Given this list of marker genes Tfap2a, here is a description of the gene set: Reactome Pathway: Specification of the neural plate border This event has been computationally inferred from an event that has been demonstrated in another species.<p>The inference is based on the homology mapping from PANTHER. Briefly, reactions for which all involved PhysicalEntities (in input, output and catalyst) have a mapped orthologue/paralogue (for complexes at least 75% of components must have a mapping) are inferred to the other species. species: Mus musculus electronically inferred by orthology from the curated human pathway part of: Gastrulation